The following is a description of a gene set: Mouse Gene Set: GOMF_RNA_2_O_METHYLTRANSFERASE_ACTIVITY species: Mus musculus Catalysis of the reaction: S-adenosyl-L-methionine + RNA = S-adenosyl-L-homocysteine + RNA containing 2'-O-methylribonucleotide., and this is the list of marker genes: Trmt13, Henmt1, Bcdin3d, Fbl, Mrm1, Mrm3, Ftsj3, Ftsj1, Mrm2